Given this list of marker genes Pofut1, B3glct, Fpgt, Fuom, Fuca1, Pofut2, Fuca2 (NCBI Gene Id 75741), here is a description of the gene set: Mouse Gene Set: GOBP_FUCOSE_METABOLIC_PROCESS studied in species Mus musculus The chemical reactions and pathways involving fucose, or 6-deoxygalactose, which has two enantiomers, D-fucose and L-fucose.